The following is a description of a gene set: Human Gene Set: GOBP_MICROVILLUS_ASSEMBLY species: Homo sapiens Formation of a microvillus, a thin cylindrical membrane-covered projection on the surface of a cell., and this is the list of marker genes: PODXL, MINK1, FSCN1, KLF5, PLD1, RAP2C, RDX, STK26, ATP8B1, ESPN, RAP2B, RAPGEF6, MAP4K4, NHERF1, RAP1B, TNIK, RAP1GAP, RAP2A, RAPGEF2 (Rap guanine nucleotide exchange factor 2), EZR, FXYD5, RAP1A, MYO1A